Given this list of marker genes MIR181B1, AKT1, CLU, KLF2, APP, ESR1, HSP90AA1, NFATC3, NPY, PTX3, TMEM106A, PKD2, JAK2, CLEC7A, TLR4, ITGB2, AGXT2, STAT1, TLR5, PIK3CB, SMAD3, TLR6, HIF1A, ASS1, APOE, IL1B, HBB, KLF4, DDAH1, IFNG, PTGS2, EDN1, INSR, TNF, KLRC4-KLRK1, TICAM1, CD36, HSP90AB1, P2RX4, KLRK1, SOD2, MIR99B, MIR181A2, ASL, DDAH2, here is a description of the gene set: species: Homo sapiens Human Gene Set: GOBP_POSITIVE_REGULATION_OF_NITRIC_OXIDE_METABOLIC_PROCESS Any process that activates or increases the frequency, rate or extent of nitric oxide metabolic process.